The following is a description of a gene set: Partial absence of thumb species: Homo sapiens The absence of a phalangeal segment of a thumb. Human Gene Set: HP_PARTIAL_ABSENCE_OF_THUMB, and this is the list of marker genes: LMBR1 (NCBI Gene Id 85501), TRIO, FGFR2, VAC14, FIG4, XRCC2 (X-ray repair cross complementing 2), TBX5, FANCD2, SHH